The following is a description of a gene set: species: Homo sapiens Human Gene Set: WP_NETRINUNC5B_SIGNALING Netrin-UNC5B signaling, and this is the list of marker genes: ITGB4, MAPK14, PTK2, RAF1, RLF, CCL2, NEO1, MAP2K2, CASP3, CDH5, RHOA, DCSTAMP, JUN, TNF, PPP1CA, MAPK3, ICAM1, VCAM1, PTPN11, UNC5B, FYN, AKT1, PTPA, NTN4, INPP5D, NTN3, AGAP2, KDR, MAPK1, COL1A1, SELE, PIK3CA, SRC, ROBO4, MAP2K1, NTN1 (NCBI Gene Id 9423), ALPL, PRKCA, CCN2, CIP2A, RGMA, IL1A, PPP2R1B, TP53, IL10, YAP1, MYF5, DAPK1, RAC1 (Rac family small GTPase 1), PLEKHH1, PTK2B, ARHGEF12